Given this list of marker genes Kcng2 (NCBI Gene Id 240444), Kctd6, Hfm1, Rgs2, Fmr1, Slc10a7, Gsdmc2, Fzd4, Ubap1, Ccl20, Tmem67, Nup58, Arhgap6, Bicd1, Map3k2, Cpne8, Npr3, Chd2, Cdc42se2, Nxpe3, Scn3b, Asxl1, Epha5, Barhl2, Cdh9, Dtd2, Hipk3, Potefam3b, Tafa1, Utp23, Dgkb, Atf1, Slc25a36, Rgs17, Mynn, Rrm1, Arhgef38, N4bp2l2, Itga4, Cxadr, Fam53a, Kcmf1, Il1b, Ptger2, Fmo5, Tspan12, Fbxo8, Sall1, Gpr15, Zfp943, Dusp10, Mink1, Fezf1, Potefam3e, Rap2c, Tm6sf1, Stom, Ccr7, Gria2, Hacd2, Stam, Rngtt, Cd24a, Sephs1, Vmn2r28, Cbll1, Cadm2, Rbbp7, Nox4, Tnik, Atp11c, Vstm2a, Chic1 (cysteine-rich hydrophobic domain 1), Ell2, Tmem35a, Utrn, Eif4a1, Faah (NCBI Gene Id 14073), Syn2, Rora, Brd8, Tnfsf11, Polg2, Afg3l2, Fut9, Wnk3, Herpud1, Cntrl (NCBI Gene Id 98835), Akap5 (NCBI Gene Id 70774), Osm (NCBI Gene Id 18413), Larp4b, Chgb, Arfip1, Sh3kbp1, Cenatac, Eaf1, Impg2, Kdelr1, Zfp654, Potefam3a (POTE ankyrin domain family member 3A), Atxn1, Chmp5, Klhl29, H2-M10.6, Lax1, Ubqln2, Ipcef1, here is a description of the gene set: from publication Chen Y, Wang X (PMID 31504780) studied in species Mus musculus Mouse Gene Set: MIR_6983_3P Genes predicted to be targets of miRBase v22 microRNA mmu_miR_6983_3p in miRDB v6.0 with MirTarget v4 prediction scores > 80 (high confidence targets).